Given this list of marker genes RALA, NEURL1, NLGN1, FGD2, SPATA13, EPHB2, CLN3 (CLN3 lysosomal/endosomal transmembrane protein, battenin), CDC42, ZMYND8, TENM2, PPP1R9B, PIK3R1, STAU2, TGFB3, PRKCD, CCL21, FGD5, TENM1, TTYH1, RAB3IP, PLPPR5, MYO3A, S1PR2 (NCBI Gene Id 9294), MIEN1, NRP1, PPP1R16B, MYO3B, RHOQ, SRGAP2, ITGB4, SRF, TRPM2, DAAM2, SPAG6, TGFBR1, VSTM5, SRGAP2C, ARHGEF4, RIPOR2, AGRN, GAP43, ARHGAP44, ABITRAM, RAB5A, DMTN, FMR1, WASL, FGD1, FGD3, EZR, FNBP1L, FSCN1, SPEF1, ARF6, DOCK11, DPYSL3, FGD6 (NCBI Gene Id 55785), MYO10, FMNL3, RAB17, FGD4, ARAP1, DNM3, GPM6A, NRXN1, PALM, CD2AP, CCR7, here is a description of the gene set: The assembly of a filopodium, a thin, stiff protrusion extended by the leading edge of a motile cell such as a crawling fibroblast or amoeba, or an axonal growth cone. Human Gene Set: GOBP_FILOPODIUM_ASSEMBLY species: Homo sapiens